Given this list of marker genes DACT3, SFRP1, OVOL2, MARK1, USF3, FOXA2, VEGFA, MIR149, MIR379, MIR204, SPRY1, DSG2, TRIM62, KAT8, MIR18A, GATA3 (GATA binding protein 3), SPRED2, ZNF750, ADIPOR1, MIR29B1 (microRNA 29b-1), MIR19B1, EPHA4, GSK3B, LDLRAD4 (NCBI Gene Id 753), SPRED3, TGFB2, MIR590, FUZ, MIR302B, MIR142, MIR130A, SDHAF2, MIR145, MAD2L2, FOXA1 (forkhead box A1), FBXO11, PTEN, SMAD7, SFRP2, MIR202, PPP2CA, BMP5, EFNA1, NKX2-1, HPN, MIR19A, MIR144, DAB2IP, NOG, VASN, MIR372, TBX5, SPSB3, MIR573, SPRED1, IL17RD, SPRY2, here is a description of the gene set: Human Gene Set: GOBP_NEGATIVE_REGULATION_OF_EPITHELIAL_TO_MESENCHYMAL_TRANSITION studied in species Homo sapiens Any process that decreases the rate, frequency, or extent of epithelial to mesenchymal transition. Epithelial to mesenchymal transition where an epithelial cell loses apical/basolateral polarity, severs intercellular adhesive junctions, degrades basement membrane components and becomes a migratory mesenchymal cell.